Given this list of marker genes CFAP65, HPGD, KAT7, C22orf23, DANT2, ANOS1, SPACA3, TRIM64EP, OR2L1P, PRSS1, CITED1, VHL, LINC00642, PELI2, CYP3A7, DLX5, ANKRD36BP2, DPEP2, CFC1, CRYGA, IZUMO1, SLC25A21, BMP7, TMEM196, KIF24, MYOG, TFAP2E, LINC00221, CD83, HEATR9, LIN54 (lin-54 DREAM MuvB core complex component), C16orf82, SLC9A9, F2RL3, F11, UNC79, NSMCE1-DT, POM121L10P, MMP20, CBR3-AS1 (CBR3 antisense RNA 1), MAP10, CERNA1, CPNE5, CALML5, SVBP, DQX1, LINC00330 (long intergenic non-protein coding RNA 330), ZBTB8B, PRKD1, GAL3ST2, SLC25A44 (solute carrier family 25 member 44), NSF, USP3-AS1, DGCR5, PPIL6, GPRASP3, VXN, APLF, NKRF, TRAM2, NAT8 (N-acetyltransferase 8 (putative)), COL11A2, KLF15, CXCL2, FETUB, CLEC4A, LINC00910, RALGAPA1, PSORS1C2, PMEPA1, TEX38, BLOC1S6, PSD2, MIR9-1HG, ZNF784, TRAK2, SVOPL, NKX2-8, HES2, TMCO5B, TBX1, KSR2, NUMBL, TMEM235 (NCBI Gene Id 283999), ADAM18, CCL28, IL21R-AS1, OR5P3, THAP7-AS1, FAHD2A, CCL21, ASTN1, PCDHB5, HOPX, ADHFE1, BEAN1, BCDIN3D-AS1, H4C2, LINC00887, CHAT, KIR2DS5, THAP8, CAV1, OR5AK4P, SCN4B, FAM185A, GPSM2, OPN4, WFDC10B, LRATD2, SLC2A4, PID1, ENOX2, KLK8, POC5, ELMOD1, NECAP2, USH2A, MYH1, EPB41L2, C11orf16, ERICH6, SPATA8, SWI5, LINC00205, GJA1, RNF135, POU5F1P4, DDX19B, GALNTL5, NIPAL2, SMIM31, TAS2R8, HEATR5B, CA13, RNF152, NDP, ARHGAP35, SCOC-AS1, FBXL13, SOX21, KLKB1, SLC6A5, LRRC74B, NR5A2, REG1B (regenerating family member 1 beta), LPAR2, BNIPL, NAA38, ADAM5, HCG11, ENSG00000248540, ACP4, OPRK1, LUZP2, MIEF2, ENSG00000230725, TBX5, ZBTB46, LPP-AS2, ERLIN1 (NCBI Gene Id 10613), ZNF497, CLTRN (collectrin, amino acid transport regulator), TRPV1, ENSG00000124835, KHDRBS2, EFCAB12, FZD10, ZNF394, GAPT, MAPKAP1, ASB15, SLC17A3, SIT1, CNGA4, MYH3, RPGR, LINC02112, TTC28, BAALC-AS1, OVOL2, CHGA, here is a description of the gene set: Removal of the transcription factor SAP1a member of the Ternary Complex Factor (TCF) group of transcription factors which in conjunction with Serum Response Factor (SRF) has been shown to have a profound effect on positive selection in the thymus. When another TCF Elk1 is knocked out in mice there is no effect on positive selection unless it is on a Sap1a KO background where the phenotype is very severe. We have stimulated isolated double positive T cells (DPs) with anti-CD3 to mimic positive selection and compared basal and stimulated transcription across the four genotypes to discover the downstream targets of Sap1a involved in positive selection. Genes down-regulated in double positive thymocytes with ELK4 knockout: untreated versus stimulated by anti-CD3. species: Homo sapiens Human Gene Set: GSE21546_UNSTIM_VS_ANTI_CD3_STIM_SAP1A_KO_DP_THYMOCYTES_DN from publication Costello P, Nicolas R, Willoughby J, Wasylyk B, Nordheim A, Treisman R (PMID 20554967)